Given this list of marker genes GREM1, CD93, TGFBI, TWIST2, COL6A1, COL6A3, IL1RN, DFFB, TPSD1, MVK, MGP, CD53, SPRR1A, CTSH, HSPB8, THBD, CAP1, ENPP2, HOXC8, ACADM, GAS1, HNF1B, CCL15, COL6A2, ARHGDIB, RSPO2, FOXC2, MGLL, GATA6, PITX2, CDKN1B, LIMK1, THBS2, here is a description of the gene set: studied in species Mus musculus Human Gene Set: SCHRAETS_MLL_TARGETS_DN from publication Schraets D, Lehmann T, Dingermann T, Marschalek R (PMID 12789274) Genes down-regulated in fibroblasts from MLL knockout mice. The human mixed lineage leukemia (MLL) gene is involved in about 50 different chromosomal translocations, associated with the disease phenotype of acute leukemia. However, the normal function of MLL is less understood. Homozygous knockouts of murine Mll were embryonal lethal, while heterozygous disruption led to aberrant hox gene expression associated with skeletal malformations, growth retardation, and impaired hematopoiesis. To understand MLL functions on the molecular level, gene expression profiling experiments were performed with a pair of murine cell lines (MLL(+/+) and MLL(-/-)). Microarray hybridization experiments revealed 197 potential target genes that are differentially expressed, providing new and important clues about MLL functions.